Given this list of marker genes HRAS, CDC37 (NCBI Gene Id 11140), RPS27A, HSP90AA1, GRB2, CBL, EGFR, UBC, UBB, PIK3CA, PIK3R1, KRAS, GAB1, EGF, NRAS, UBA52, SHC1, SOS1, PLCG1, here is a description of the gene set: Reactome Pathway: Constitutive Signaling by Ligand-Responsive EGFR Cancer Variants part of: Signaling by Ligand-Responsive EGFR Variants in Cancer Signaling by EGFR is frequently activated in cancer through activating mutations in the coding sequence of the EGFR gene, resulting in expression of a constitutively active mutant protein. <br><br>Epidermal growth factor receptor kinase domain mutants are present in ~16% of non-small-cell lung cancers (NSCLCs), but are also found in other cancer types, such as breast cancer, colorectal cancer, ovarian cancer and thyroid cancer. EGFR kinase domain mutants harbor activating mutations in exons 18-21 which code for the kinase domain (amino acids 712-979). Small deletions, insertions or substitutions of amino acids within the kinase domain lock EGFR in its active conformation in which the enzyme can dimerize and undergo autophosphorylation spontaneously, without ligand binding (although ligand binding ability is preserved), and activate downstream signaling pathways that promote cell survival. <br><br>Point mutations in the extracellular domain of EGFR are frequently found in glioblastoma. Similar to kinase domain mutations, point mutations in the extracellular domain result in constitutively active EGFR proteins that signal in the absence of ligands, but ligand binding ability and responsiveness are preserved. <br><br>EGFR kinase domain mutants need to maintain association with the chaperone heat shock protein 90 (HSP90) for proper functioning. CDC37 is a co-chaperone of HSP90 that acts as a scaffold and regulator of interaction between HSP90 and its protein kinase clients. CDC37 is frequently over-expressed in cancers involving mutant kinases and acts as an oncogene. <br><br>Over-expression of the wild-type EGFR or EGFR cancer mutants results in aberrant activation of downstream signaling cascades, namely RAS/RAF/MAP kinase signaling and PI3K/AKT signaling, and possibly signaling by PLCG1, which leads to increased cell proliferation and survival, providing selective advantage to cancer cells that harbor activating mutations in the EGFR gene. <br><br>While growth factor activated wild-type EGFR is promptly down-regulated by internalization and degradation, cancer mutants of EGFR demonstrate prolonged activation. Association of HSP90 with EGFR kinase domain mutants negatively affects CBL-mediated ubiquitination, possibly through decreasing the affinity of EGFR kinase domain mutants for phosphorylated CBL, so that CBL dissociates from the complex upon phosphorylation and cannot perform ubiquitination. <br><br>Various molecular therapeutics are being developed to target aberrantly activated EGFR in cancer. Non-covalent (reversible) small tyrosine kinase inhibitors (TKIs), such as gefitinib and erlotinib, selectively bind kinase domain of EGFR, competitively inhibiting ATP binding and subsequent autophosphorylation of EGFR dimers. EGFR kinase domain mutants sensitive to non-covalent TKIs exhibit greater affinity for TKIs than ATP compared with the wild-type EGFR protein, and are therefore preferential targets of non-covalent TKI therapeutics. EGFR proteins that harbor point mutations in the extracellular domain also show sensitivity to non-covalent tyrosine kinase inhibitors. EGFR kinase domain mutants harboring small insertions in exon 20 or a secondary T790M mutation are resistant to reversible TKIs due to increased affinity for ATP, and are targets of covalent (irreversible) TKIs that form a covalent bond with EGFR cysteine residue C397. However, effective concentrations of covalent TKIs also inhibit wild-type EGFR, causing severe side effects. Hence, covalent TKIs have not shown much promise in clinical trials (Reviewed by Pao and Chmielecki in 2010). studied in species Homo sapiens